The following is a description of a gene set: studied in species Mus musculus Generic Transcription Pathway Mouse Gene Set: REACTOME_GENERIC_TRANSCRIPTION_PATHWAY, and this is the list of marker genes: Maml3, Foxo3, Zfp655, Aurka, Cenpj, Prkag3 (protein kinase, AMP-activated, gamma 3 non-catalytic subunit), Prelid1, Ercc2, Actl6b, H4c1 (NCBI Gene Id 326619), Cox5b, 2610021A01Rik, Npas4, Psmd1, Ldb1, Hdac1, Cdk6, Rnf2, Elf1, Zfp712, Zfp1005, Cbx6, H2ac8, Zfp382, Zfp931, Smyd2, Rfc2, Zfp445, mt-Co3, Ywhaq, Jmy, Zfp704, Tbl1xr1, Tbl1x, Zfp35, Cox6b2, Tfap2e, BC051665, Tead4, Zfp963, Taf13, Zfp202, H2bc26, Zfp658, Steap3, Gtf2h2, Mapk14, Polr2h, Meaf6, Rad17, Rpa1, Rptor, Taf2, Cnot4, Foxo1, Prkab2, Thra, Esr2, Pip4p1, Zfp84, Mapk1, Smarcc2, Gtf2h4, Med1, Zfp974 (zinc finger protein 974), Krba1, H3c7, Prmt6, H2ab2, Zfp747, Esrrb, Gm21411, Zfp112, Adrm1, Zfp457, H4c4, Csnk2a1, H2bc21, Zfp268, Ezh2, 4930522L14Rik, Lmo2, H3c8, Plk3, Nr5a1, Gsr, Csnk2a2, Mlst8, Zfp74, H3f3b, Mapk3, Zscan25, Polr2g, Ctnnb1, Zfp418, Ywhag, Topbp1, Zfp975, Gm15446, Zfp773, Rragb, Zfp747l1, Gm32687, Prdx5, Taf9b, H3c13, Zfp354b, Zfp78, Arnt, Maged1, H2ac7, Zfp455, Rara, Nr4a2, Zfp61, Ndufa4, Ccnk, Zfp599, Gm10053, Ak6, Bmi1, Zfp426, Polr2l, Mecp2, Hdac6, Ppard, Psmd7, Nr2c1, Yap1, Zfpm1, Sirt1, Zfp688, Zfp780b, Serpinb13, Zfp420, Rslcan18, Psmc3, Uba52, Rxra, Cdk13, Maml1, Tmem219, E2f4, Tcf3, Zfp282, Blm, Cbx2, Pbrm1, Tfap2a, Pip4k2b, Gm10778, Zfp248, Cox4i2, Zkscan1, Pou4f2, Ddit4, Zfp54, Rad9a, Zfp28, Zkscan3, Krbox5, Nelfa, Polr2k, Polr2f, H3c2, Banp, Foxo6, H4c12, Gls2, Trp53, Lamtor4, H4c2, Cox4i1, Hdac4, Lamtor3, Zfp582 (NCBI Gene Id 100416477), Atrip, Tfdp1, Cdk1, Cbfb, Cdk4, Mnat1, H3c10, Zfp354c, Dek, Zfp85 (zinc finger protein 85), Rbm14, Psma2, Tigar, Zfp58, Zfp595, Ctcf, Runx2, Pdpk1, Smad2, Zfp97, H2bc11, Zfp566, Chek2, Zfp446, Ubc, Zfp69, Rbpj, Pidd1, Gata3, Psmb4, H4c17, H4c6, Cox7b, Cnot8, Zfp874a, Zfp65, Zfp799, Ehmt2, Txnrd1, Psmc6, Cnot6l, Psma4, Nr1h4, Zkscan4, Hipk1, Foxo4, Zfp37, Pgr, Gatad2b, Abl1, H3c15, H2bc14, Cdk5, Cdkn1a, Src, Zfp775, Mga, Rad1, Tead3, Rragd, H2ac10, Tcf7l2 (transcription factor 7 like 2, T cell specific, HMG box), Ercc3, Nbn, Hdac11, Atad2, Rorc, Zfp175, Psmc2, H2ac24, Daxx, Zfp458 (zinc finger protein 458), Ppp2cb, Rmi1, Nr0b2, Phc3, Zfp866, Zkscan16, Nr1i2, H2ac23, H2bc22, Rictor, Zfp937, Ccnt1, Polr2d, H2ac20, Zfp940, Slc38a9, Zfp169, H2bc13 (H2B clustered histone 13), Notch4, Gm14444 (predicted gene 14444), Taf9, Zfp60, Sesn2, H4c8, Ring1, Sgk1, Atm, Gm14399, Atp1b4, BC024063, Zfp473, Rfc4, Gtf2h1, Parp1, Zfp94, Taf12, Zfp748 (NCBI Gene Id 69205), Zfp961, Lef1, Zkscan7, Pml, Chek1, Gadd45a, Rxrb, Psmb6, Psma3, Rbbp7, Smurf2, Smad4, Zfp617, Max, Tfap2b, Taf6, Psmd11, Notch3, H3f3a, G6pdx, Nr4a3, Scmh1 (NCBI Gene Id 29871), Eloc, H2ac15, Pax5, Psmd14, Zfp872 (NCBI Gene Id 619310), Cradd, Cox8c, mt-Co1, Tbx5, Nr1d1, Mapkapk5, Brca1, Zfp90, Gpi1, Cdk5r1, Ccne1, Brd1, Tgif1, Esr1, Cox7c, Psmd13, Zfp1007, Nr5a2, Nr1h2, Zfp317, Smarce1, Zfp472, Notch1, Prkag1, Ccnd1, Gm6871, Zfp759, Skp1, Prr5, Cox8a, Cnot3 (NCBI Gene Id 320303), Zkscan14 (zinc finger with KRAB and SCAN domains 14), Zfp846, Trp73, H3c1, Zfp874b, Zfp746, Nuak1, Zfp738, Nr1d2, Btg2, Rbbp4, Smarcd3, Zfp710, Zfp764, Zfp53, Skp2, Cox6a2, H2bc24, Wdr5, Rraga (NCBI Gene Id 68441), Zfp664, Zfp970, Cdk12, Ppm1a, Zfp661, Nr3c2, Pip4k2c, Cited2, Npm1, Cnot6, Rmi2, Lhb, Zkscan6, H3c11, Kat6a (K(lysine) acetyltransferase 6A), H2bc6, Psma7, Cdkn1b, Kmt2a, Chm, Kat2b, Psmb5, Ccne2, Setd1b (SET domain containing 1B), B020011L13Rik, Trp53inp1, Cox6c, Mtor, Zfp997, Kat5, Smad3, Ppp1r13l, H2ac19, Bard1 (NCBI Gene Id 12021), Men1, Cox7a2l, Taf1, E2f6, Bnip3l, Sirt3, H4c18, Ccnt2, Tgfb1, Phc1, Trp53bp2, Higd1c, Zfp934, Arnt2, Hdac5, Dyrk2, H4c11, Cbx4, Zfhx3, Psmd3, Zfp184, Sesn1, Gata1 (NCBI Gene Id 14460), Psmd12, Psma6, Cnot11, Zfp689, Zfp429, Chd3, Tsc1, Zfp786, Taf4b, H2ax, H4c16, Cdkn1c, Gm3604 (predicted gene 3604), Nr2e3, Zfp1, Mta2, Nr1i3, Cnot10, Smarca4, Brpf3, Prmt1, Zfp324, Zfp141, Zfp13, Nr2f6, H2ab1, Zfp804b, Tcf7, Brd7, Zfp703, E2f7, Eloa, Psmb2, H2ac13, Rheb, Csnk2b, Ctsl, Smarcd2, Akt3, Mapkap1, Zfp551, Gtf2f2, Zfp788, Skil, H3c3, Zfp740, Polr2b, Zfp839, Zfp213, H2ac22, Usp9x, Zfp87, Rbbp5, Rsl1, Smad7, L3mbtl1, Tfap2d (transcription factor AP-2, delta), Ube2d3, Ccna2 (cyclin A2), Zfp770, Lamtor5, Sin3b, H2bc4, Polr2c, Gtf2f1, Ptpn11, Ppp2r1b, Tcf12, Gm19965, Zfp433, Exo1, Sox9, Supt16, Trim28, Tgif2, Zfp160, Zfp867, H3c6, Polr2e, Thrb, Foxg1, Hdac7, Taf7, Smad1, Cycs, Tfap2c, Zik1, Hdac8, Rnf111, Cdk9, Gtf2h3, Cdk7, Rfc5, Ubb, Zfp386, Nrbf2, Akt1, Cdc25c, Ube2d1, Zfp978, Ube2i, Zfp189, Zfp456, Ing2, Nelfb, Zfp212, Cnot2, Psmc4, Dna2, Cited4, Nr4a1, Zfp558, Ncor2, Zfp708, Prdx2, Gls, Bmal1, Ywhae, Mdm4, Sumo1, E2f5, Prkaa2, Cnot7, Rabggtb, Rhno1, Rbx1, Zfp180, mt-Co2, Vdr, Zfp870, Ccnd3, H4c9, Rbbp8, Stk11, Tead2, Zfp964, Mre11a, Rps27a, Psmb1, Sfn, Rad50, Rxrg, Lmo1, Psmc5, Zfp612, Psmb3, H2ab3, H2bc9, Yeats4, Stub1, Hdac3, Uba52rt, Ccna1, Hipk2, Kmt5a, Epc1, H2bc8, Foxp3, Zfp385a, Ppp2r1a, Ing5 (inhibitor of growth family, member 5), Lbr, Zfp263, Brpf1, Nedd4l, Tpx2, Zfp354a, Psmd8, Ppara, Zfp383, Mbd3, Psmd2, H2bc15, Rora, Zfp750, Taf3, Zfp938, Zfp869, Cox7a1, Rarg, Zfp941, Zfp976, H2bc12, Zkscan5, Gatad2a, Usp7, Sesn3, Itch, Aurkb, Tcea1, Zfp706, Triap1, Gm14412, Myc, Ttc5, Supt5, Ywhaz, E2f8 (E2F transcription factor 8), Ski, Prkag2, Cga, H2bc7, Supt4a, Cox5a, Chd4, Ell, Nr2f1, Actl6a, Auts2 (autism susceptibility candidate 2), Yaf2, Pou4f1, Zfp764l1, Mdm2, Ppp2r5c, Zfp229, Runx3, Nelfcd, Tsc2, Pcna, Zfp583, Zfp1004, H2bc1, Prkab1, Pin1, H2ac12, H2ac4, Pcgf2, Sin3a, Noc2l, Cdk8, Ehmt1, Cul1, Ywhah, Cbx8, Rpa2 (NCBI Gene Id 99984), Ywhab, Zfp619, Smarcd1, Zfp667, Zfp641, L3mbtl2, Rorb (RAR-related orphan receptor beta), Pip4k2a, Zfp12, H2ac11, Tcf7l1, H3c4, Kctd1, Lamtor2, Nr2e1, Ep300, Top3a, Rnf34, Zfp677, Zfp729a, Zfp30, Psmb7, Pcgf6, Zfp960, Zfp454, Smarcb1, Zfp605, Gtf2h5, Tbp, Hus1, Rarb, Brip1, Rbl1, Psmd6, Rfc3, Cox6b1, Gm5141, Gm4767, Zfp932, Ppp2ca, Zfp993 (NCBI Gene Id 115486238), Zfp873, H2ac6, Wwtr1, Nr6a1, Phc2, Prelid3a, Taf10, Suz12, Polr2i, H2az2, H2aj, Zfp235, Lamtor1, Esrrg, Bax, Gpx2 (NCBI Gene Id 14776), Mamld1, Kdm5b, Zfp113, Kmt2b, Map2k6, Taf5, Setd1a, H4c3, Zfp2, Elob, Hdac10, Rffl, H4c14 (H4 clustered histone 14), Mapk11, Zfp345, Cox6a1, Txn1, Prdx1, Ppm1d, Ccnc, Esrra, Nr0b1, Nr3c1, Zkscan17, H2ac18, Zfp606, Zfp954, Cdk2, Wwox, Zfp950, Cited1, Cnot1, Trp53rkb, Smurf1, Zfp868, Zfp286, Zfp267, H2bc3, Zkscan8, Sp1, Ccnd2 (cyclin D2), Psma1, Ctdp1, Zfp735, Zfp563, Rpa3, Zfp273, Zfp9, Zfp11, Ccnb1, Prkaa1, Ccnh, Arid1a, Zfp696, Kat2a, Tead1, Plk2, Zfp711, Elf2, Cox7a2, Usp2, Ssrp1, Casp2, Zfp26, Zfp647, Zfp808, H3c14, Pcgf5, Ash2l, Nr2c2, Gata2, Ppp1r13b, Ctsk, Zfp68, Nr1h3, Cnot9, Eed, Polr2a, Prmt5, Kmt2d, Zfp398, Psmc1, Furin, Taf4, Wrn, Zfp39, Zfp760, Taf15, Zfp442, Igfbp3 (insulin-like growth factor binding protein 3), Rabggta, Smarcc1, Zfp14, H2bc23, Rybp, Nelfe, Ccng1, Zfp871, Zfp811, Zfp772, Maml2, Rad9b, Akt2, Hnf4a, Taf11 (TATA-box binding protein associated factor 11), Ar, Tal1, Phf20, Rragc, Tnks1bp1, Trp63, Psma5, Atxn3, Zfp27